The following is a description of a gene set: studied in species Mus musculus Mouse Gene Set: GOCC_R2TP_COMPLEX A highly conserved protein complex comprised of two ATP-dependent DNA helicases (Rvb1p and Rvb2p in yeast, Pontin52 and Reptin52 in humans), Pih1p in yeast or PIH1D1 in humans, and Tah1 in yeast or RPAP3 in humans. The complex associates with Hsp90 and is thought to have a role in assembly of large protein or protein/nucleic acid complexes. In this role it is involved in multiple processes such as box C/D snoRNP biogenesis, phosphatidylinositol-3 kinase-related protein kinase (PIKK) signaling, RNA polymerase II assembly, and others., and this is the list of marker genes: Pih1d2, Ruvbl2, Ruvbl1, Pih1d1, Rpap3